The following is a description of a gene set: Reactome Pathway: SLBP independent Processing of Histone Pre-mRNAs This class of mRNAs is expressed from genes that lack introns yet the transcripts end in polyA tails. These tails are formed by a mechanism similar to that for pre-mRNAs containing introns. It is believed that there is a cis-element that replaces the 3' splice site that normally serves to activate polyadenylation of intron containing pre-mRNAs. studied in species Homo sapiens part of: Processing of Capped Intronless Pre-mRNA, and this is the list of marker genes: ZNF473, NCBP2, SNRPD3 (NCBI Gene Id 6634), LSM10, SNRPF, LSM11, SNRPB (NCBI Gene Id 6628), SNRPE, SNRPG, NCBP1